The following is a description of a gene set: electronically inferred by orthology from the curated human pathway part of: Metabolism of nitric oxide: NOS3 activation and regulation studied in species Mus musculus This event has been computationally inferred from an event that has been demonstrated in another species.<p>The inference is based on the homology mapping from PANTHER. Briefly, reactions for which all involved PhysicalEntities (in input, output and catalyst) have a mapped orthologue/paralogue (for complexes at least 75% of components must have a mapping) are inferred to the other species. Reactome Pathway: NOSIP mediated eNOS trafficking, and this is the list of marker genes: Nosip